The following is a description of a gene set: Pathway Definition from KEGG: TLR3 -> TICAM1 -> TRAF3 -> (IKBKE+TBK1) -> IRF7 => IFNA studied in species Homo sapiens TLR3-IRF7 signaling pathway. Pathway ID: N00148. Pathway type: Reference. Pathway class: nt06517 TLR signaling. Human Gene Set: KEGG_MEDICUS_REFERENCE_TLR3_IRF7_SIGNALING_PATHWAY, and this is the list of marker genes: IFNA7, TICAM1, IFNA13, IFNA21, TBK1, IFNA17, IFNA2, TRAF3, IFNA16, IFNA10, IFNA14 (NCBI Gene Id 3448), IFNA8, IKBKE, IFNA4, IRF7, IFNA1, IFNA6, TLR3 (NCBI Gene Id 7098), IFNA5